Given this list of marker genes DUSP8, MAPK1, DUSP7, DUSP16, DUSP9, DUSP10, DUSP6, here is a description of the gene set: species: Homo sapiens Signaling by MAPK mutants Human Gene Set: REACTOME_SIGNALING_BY_MAPK_MUTANTS